The following is a description of a gene set: Genes predicted to be targets of miRBase v22 microRNA hsa-miR-765 in miRDB v6.0 with MirTarget v4 prediction scores > 80 (high confidence targets). Human Gene Set: MIR765 studied in species Homo sapiens from publication Chen Y, Wang X (PMID 31504780), and this is the list of marker genes: GAB2, FAIM2, MYO18B, CYB5R2, FAM169BP, MON1B, TNFRSF14, PCDHGA1, PCDHGB1, GTPBP1, DENND2C, PCDHGB3, KAZALD1, GPR62, PTCH2, DCX, PLA2G3, SCFD2, HRK, SERP2, COL27A1, MYO1A, SYPL2, SEH1L, STK40, PCDHGA6, ARAF, KIRREL2, PPP1R12B, LHFPL4 (NCBI Gene Id 375323), ZDHHC9, ZIC3, PCDHGA9, LAT2, HDAC5, ATXN1L, GLT6D1, PRRG4, PCDHGB7, PCDHGA12, KAT7, RAB15, ST3GAL2, PTGR3, GRIK3, DGKD, TEX2, SERPINA6, KPNA3, USP36, RIBC1 (NCBI Gene Id 158787), RUFY4, LYSMD3, SKI, HOXC4, BTN1A1 (butyrophilin subfamily 1 member A1), FAM78A, ZNF710, SEPTIN3, CCL4, DPAGT1, KLK12, OTP, SLC4A8, SPTBN4, CASKIN1, RERE, TMED10, PLP2, ZBTB45, AHDC1, SLC18A3, PCDHGC3, SDK1, G3BP2, SOCS7, CAPN6, MMP16, ISLR2, LRP4, RAB5B, CUX1 (NCBI Gene Id 1523), ARID2, MARCHF8, UPK1A, SYNE3, SP6, FAM117A, SHANK2, PXK, GPR107, SIPA1L3, TNS1, TPCN1, MACROH2A2, PTAFR, POM121, ADAM12, CLSTN1, MYCN, KCNC4, MTUS1, PSD2, LMO7DN, CD164L2, SHISA6, CD34, NDUFA4L2 (NDUFA4 mitochondrial complex associated like 2), ASB16, RPH3A, TMEM26, DLX3, DENND1A, ADGRG5, CAPN3, FXYD3, CTDSP1, SIX3 (SIX homeobox 3), GALP, TRIM66, PAXBP1, SPRR4, NUTF2, POLI, HOMER1, TOR2A, S100A7A, DPF3, CARTPT, ZNF784, CNTFR, HEYL, PCDHGA7, KCND1, SP2, TESMIN, CORO2B, PCDHGB2, PCDHGA4, LHPP, PCDHGB5, EEIG1, C11orf87, MTCL2, CEACAM6, YWHAG, UNC5B, TANC2, RAB6A, HSPBP1, RBM20, PCDHGA11, MTSS2, GRIN2B, C5AR1, NBR1, EZH1, EPSTI1, RAD51B, ZNF444, PCDHGC4, ZNF396, PRIMA1, RND2, HLA-DQA1, SEC61A2, XYLB, KLK4, KDM2A, HLA-DQA2, PRRC2B, JPH4, TRIM67, WDR59, CNTNAP1, ANKRD40 (NCBI Gene Id 91369), CACNG7, PCDHGB6, POLR2F, FBXO21, LINGO1, ELK1, PCDHGA2, PNKD, LMLN, PRELP, HOXB5, SETBP1, PCDHGA5, ITPRIPL2, PRR5, PHF7, POU2F2, IKZF4, CXCL12, CAMK1D, PFKFB3, PDX1, BCAM, ORMDL2, TMEM233, SDK2, MDM1, CNNM4, FAM78B, KPRP, LINC02873, ISM2, TNFRSF11B, BRD4 (NCBI Gene Id 90616), C1orf226, LSAMP, HNF4A, JMJD8, EN2, ASIC1, RPRD2, CHMP1A, ARID1A, ADAM19, PUM1, N4BP3, TMEM265, PCDHGA8, CFAP77, NFIX, PSMD11, KIRREL1, DNM2, CD4, NAV1, NOVA2, CASTOR2, ZNF436, GABRA3, GPATCH1, CPLX1, COL4A6, ABCG4, TIMP3, PTPRT, PBX1, URM1, BICDL1, PRLR, PCDHGA3, DBNDD2, TCF4, CSF1R, CACUL1, RHBDF2, SLC38A7, INO80D, ZC3H12A (zinc finger CCCH-type containing 12A), CADM4, LRRC8A, GSE1, ADCYAP1R1, PCDHGB4, GFRA2, SGPP2, GLG1, ANKRD13A, LRATD2, PDE4A, VAMP2, SERPINA1, ADGRL1, CCDC28A-AS1, MECP2, C3orf80, NRBP2, PML, VPS25, CHRDL1, L3MBTL3, KIAA1671, PDE6D, CLMN, PCDHGA10, AGO1, KMO, LAMC1, PTK2B, COX10, RAD54B, TLCD3A, PCDHGC5, CDX1